Given this list of marker genes SEMA3A, SLMAP, SCN1B, TRPM4, SCN10A, SCN2B, SCNN1A, HCN4, PRKAG2, KCNE5, CACNA1C, RANGRF, KCNE3, KCND3, SCN3B, GYG1, POLG, AKAP9, CACNA2D1, PKP2, SCN5A, GPD1L, KCNJ8, ABCC9, CACNB2, here is a description of the gene set: Human Gene Set: HP_ST_SEGMENT_ELEVATION ST segment elevation An electrocardiographic anomaly in which the ST segment is observed to be located superior to the isoelectric line. studied in species Homo sapiens